The following is a description of a gene set: Mouse Gene Set: GOBP_ADENYLATE_CYCLASE_ACTIVATING_ADRENERGIC_RECEPTOR_SIGNALING_PATHWAY species: Mus musculus An adenylate cyclase-activating G protein-coupled receptor signaling pathway initiated by a ligand binding to an adrenergic receptor on the surface of the target cell, and ending with the regulation of a downstream cellular process., and this is the list of marker genes: Gpr101, Adrb1, Adra1d, Gnas, Chga, Atp2b4, Adrb2, Drd5, Arrdc3, Adrb3, Crtc3, Pln, Adra1b, Gnai2, Drd1, Adcy9, Rapgef2, Adra1a